Given this list of marker genes UXT, LDHA, ADAR, UBE2L3, LDLR, BTN2A2, GDI2, GUCY1B1, RERE, WDR1, LAX1, LAMP5, RAB4A, LRRN2, HOXC4, GPI, CHST7, TMPRSS2, MMP15, ABCG1, EHD1, MOB1A, SYNJ2, QARS1, SERPINF1, PSG6, KCNQ1, SURF1, FHL1, PHB2, LTBP4, GPR6, XRCC6, ELOC, NHERF1, CD34, FXYD5 (NCBI Gene Id 53827), MEF2A, TUFM, RARA, UTP11, C15orf39, EEF1D, RPL28, CARM1, NBL1 (NBL1, DAN family BMP antagonist), ARL4C, GRHPR, SORBS3, CLXN, RRP9, CD7, EIF3D, STK10, PES1, MLNR, ALDOA, DGKD, EIF6, PPP1R16B, LRP4, GAS6, ELAVL1, PPM1F, ACLY, LPAR6, EIF4B, EIF3F, ARID3B, DSC1, MAP4K1, RETREG1, OAZ3, MRC1, FAM162A, TCF7, here is a description of the gene set: The 'NPM1-mutated signature 2': genes down-regulated in pediatric AML (acute myeloid leukemia) samples with mutated NPM1 compared to the AML cases with the intact gene and without recurring cytogenetic anomalities or M7 phenotype. Human Gene Set: MULLIGHAN_NPM1_MUTATED_SIGNATURE_2_DN studied in species Homo sapiens from publication Mullighan CG, Kennedy A, Zhou X, Radtke I, Phillips LA, Shurtleff SA, Downing JR (PMID 17597811) Somatic mutations in nucleophosmin (NPM1) occur in approximately 35% of adult acute myeloid leukemia (AML). To assess the frequency of NPM1 mutations in pediatric AML, we sequenced NPM1 in the diagnostic blasts from 93 pediatric AML patients. Six cases harbored NPM1 mutations, with each case lacking common cytogenetic abnormalities. To explore the phenotype of the AMLs with NPM1 mutations, gene expression profiles were obtained using Affymetrix U133A microarrays. NPM1 mutations were associated with increased expression of multiple homeobox genes including HOXA9, A10, B2, B6 and MEIS1. As dysregulated homeobox gene expression is also a feature of MLL-rearranged leukemia, the gene expression signatures of NPM1-mutated and MLL-rearranged leukemias were compared. Significant differences were identified between these leukemia subtypes including the expression of different HOX genes, with NPM1-mutated AML showing higher levels of expression of HOXB2, B3, B6 and D4. These results confirm recent reports of perturbed HOX expression in NPM1-mutated adult AML, and provide the first evidence that the NPM1-mutated signature is distinct from MLL-rearranged AML. These findings suggest that mutated NPM1 leads to dysregulated HOX expression via a different mechanism than MLL rearrangement.